The following is a description of a gene set: Human Gene Set: HE_LIM_SUN_FETAL_LUNG_C7_SST_POS_NEURON_CELL from publication He P, Lim K, Sun D, Pett JP, Jeng Q, Polanski K, Dong Z, Bolt L, Richardson L, Mamanova L, Dabrowska M, Wilbrey-Clark A, Madissoon E, Tuong ZK, Dann E, Suo C, Goh I, Yoshida M, Nikolić MZ, Janes SM, He X, Barker RA, Teichmann SA, Marioni JC, Meyer KB, Rawlins EL (PMID 36493756) SST+ neuron species: Homo sapiens, and this is the list of marker genes: ZNF282, SLC18A3, SCAMP5, MARCHF1, HRK, LRRC8B, BRSK1 (BR serine/threonine kinase 1), SOBP, SH2B2, ASIC1, HAGHL, KLHDC9, DNAJC25-GNG10, OSTM1, CAMSAP3, SPINT2, SVOP, ISLR2, GRIA3, DMTN, ELMO1, RIMS2, GPRIN1, HMGCLL1, TTC39C, CPLX2, SLC18A2, ISL1, ETNK2, LIX1, SLC2A3, EIF4E3, CEND1, GRIA2, CARMIL2, MPP2, NRG2, TMEM145, RUNDC3B, PNCK, ATP6V1G2, UNC5D, RIC3, EML5, DENND6B, FNDC4, CHST1, CLSTN3, SYBU, NRP1, PNMA2, FAM241B, SCML4, TMOD1, ST8SIA2, NYAP2, RPH3AL, GPR27 (NCBI Gene Id 54330), REEP2, RET, SLCO3A1, AKR1C1, TMEM255B (transmembrane protein 255B), ASGR1, MANEAL, NELL1, PNMA6A, FGF10, LUZP2, SEMA4F, GATA3-AS1, ASTN2, PPP2R5B, LINGO1, ACTL6B, FN3K, TPPP3, KCNK10, EID2B, NT5E, NTNG1, LINC01003, FAM174B, CORO1A, INPP1, FABP3, PAK3, SLC16A3, GVQW3, PIRT, FBXO31, SLC38A1, ELAVL2, C11orf96, ATP7A, NMNAT2, ANK3, GATA3, CTIF, DIRAS1, AKAP1, CXCR4, HHIP, MTMR6, GNAO1, CNR1, CKMT1A, CYB561, MPP3, KLHL5, ICA1, SYNGR3, CPLX1, NSG2, RGS9, STK32C, POU2F2, CDK5R2, HOXD1, TMEM130, CACNB1, SORL1, RXYLT1, PLPPR2, HHIP-AS1, HCN3, TRIM67, JPH4 (NCBI Gene Id 84502), TRPV2, ARHGDIG, SMIM18, SLC10A4, EFNB3, CELF5, RCAN2 (regulator of calcineurin 2), FBXL16, MCHR1, ABCG1, NACAD, TTC9B, TMEM120A, NIPA1, TSPAN7, PTPRN, ABCC8 (ATP binding cassette subfamily C member 8), MYT1L, PACRG, VAT1L, PLPPR3, RGS17, SH2D3C, BBC3, STAMBPL1, SRRM3, SYN3, RYR2, PLPPR5, VSTM2A, ACSS2 (NCBI Gene Id 55902), FAR2, FRY, LRRC24, RAB15, PSD, GPR22, KLRG1, CHST8, PLPP4, SYT17, NPM2, TMEFF2, HSD11B1L, NAPG, EPB41L1, KLC2, NANOS1 (NCBI Gene Id 340719), ATP1A3, RTN2, ARHGEF28, SAMD14, NRG1, SLC8A1, CYGB, BCAS4, MAGEE1, AKR1C2 (aldo-keto reductase family 1 member C2), SRGAP1, ANKS1A, NOVA2, RFTN1, CACNA2D3, TBX20, LY6H, HOXB5, REEP1, ADAM22, PRUNE2, RUFY2, DIPK1A, DOC2B, MTMR7, FECH, PPP2R2B, CNTN1, NPB, GCHFR, FAM110B, NCS1, LINGO2, MAP7D2, SEPTIN3, SLC4A8, SNAP91, SYNPO2, ZNF804A, PGAM2, PFKP, CACNB3, SLC5A7, TPD52, SYN1, MARK1, NCDN, SLC17A5, FSTL5, ENTPD3, HENMT1, SYT5, PORCN, LZTS3, PRSS3, MAPK8IP1, GLT1D1, DNM3, SHANK2, SV2A, RCAN3, B3GNT4 (NCBI Gene Id 79369), EGLN3, SLC9A7, NYAP1, SST, ASTN1, SEMA4D, SEZ6L, F12, ABCB1, CDKN2D, COX7A1, KCNK3, ARG2, AMPH, GRM8, SCN3A, HTR7, ATP13A2, ACHE, TANC2, ZCCHC12 (NCBI Gene Id 257051), KIF5A, SMPD3, DUSP26, ACBD5, GABRA3, F8A1, GNE, FBXW8 (NCBI Gene Id 26259), PPM1E, HTR3A (NCBI Gene Id 3359), CELF4, MTUS1, TMEM200C, CTXN2, SCD5, PITRM1, CHRFAM7A, ATP8A2, MXRA7, PENK, C1orf216 (chromosome 1 open reading frame 216), MAP6, MAP7, CADPS, GNB5 (NCBI Gene Id 82962), RIMBP2, PHYHIPL, PPP1R1A, RAB6B, FAM89A, ARFGEF3, SCN2A, APBB3 (amyloid beta precursor protein binding family B member 3), FAIM2, PEG3, RPS6KL1, NHSL3, ARL4C, CNIH2, NALCN, PRKAR2B, EPB41L3, DPYS (dihydropyrimidinase), CALY, TMEM108, RASGEF1B, TCEAL2, FAXC, SCN3B, PTPRR, ZFR2, FAM219A, ALCAM (NCBI Gene Id 214), RGS11 (regulator of G protein signaling 11), SYT4, HES4, RIMS1, TG, HID1, NUBPL, DCLK1, SPTBN2, MEIS3, SH3GL3, DPF1, LRFN2, DIABLO (diablo IAP-binding mitochondrial protein), PPP1R13B, PTGER3, TRIM36, PIANP, DPP6, RPS6KA2, OGDHL, RGS4, NRCAM (neuronal cell adhesion molecule), SULT4A1, CXXC4, VSTM2L, CAMK2B, TMEM255A, PLXNC1, TH, RAB3B, SNCG, RGS7 (NCBI Gene Id 6000), MAGI2, DNER, SNX10, TMEM54, CIB2, TAC3, SPOCK1, MAST1, EFNA3, GRK5, DLGAP1, SLC37A1, BOK, LIN7B, KCNMA1, LAYN, TOX2, ABCA3, MACROD2, PPEF1, PDE10A, ERC2, VWA5A, PAK5, PLD5, SH3GL2, LTK, MAPK8IP2, PRKCZ, PSD3